Given this list of marker genes Sos1, Pak4, Cyfip2, Csk, Itga1, Myl3, Fgf15 (NCBI Gene Id 14170), Pfn1, Pik3cg, Ins1 (NCBI Gene Id 16333), Wasf2, Baiap2, Pik3ca, Rras, Pik3r4, Diaph1, Rassf7, Vil1, Chrm3, Rras2, Myl1, Fgf13, Vcl, Mapk4, Fgf17, Cfl2, Apc, Fgf16, Mapk6, Fgf4, Ssh1, Crk, Pik3r2, Mylk, Pak1, Rock1, Msn, Chrm2, Fgfr2, Rac3, Pxn, Cfl1 (NCBI Gene Id 12631), Arhgef1, Iqgap1, Pip4k2b, Fgf2, Mapk1, Gna13, Pip4k2a, Arhgef6, Pik3c3, Nckap1, Fgf9, Apc2, F2, Pip5kl1, Enah, F2r, Rock2, Fgf14, Egfr, Ppp1r12a, Mos, Map2k1 (mitogen-activated protein kinase kinase 1), Fgf18, Pip5k1b, Brk1, Pik3cb, Fgf1, Rdx, Fgfr1, Fgf6 (fibroblast growth factor 6), Map2k2, Chrm5, Arhgef4, Fgd1, Fgf10, Fgfr4, Chrm4, Pik3c2b, Ins2, Abi2, Rac1, Pik3r3, Pdgfb (platelet derived growth factor, B polypeptide), Pik3cd, Mapk3, Wasf1, Fgfr3, Vav1, Fgf12, Mras, Sos2, Ptk2, Kras, Pak5, Bdkrb1, Bdkrb2, Pak2, Fgf23, Pik3c2g, Pik3c2a, Pik3r1, Actb, Fgf3, Actn1, Ssh3, Pdgfa, Slc9a1, Rac2, Braf, Chrm1, Fgf8, Ezr, Fgf22, Pak3, Cd14, Pip5k1a, Was, Fgf7, Pdgfra, Fgf21, Nras, Bcar1, Actg1, Cdc42, Tmsb4x, Myh10, Fgf20, Git1 (NCBI Gene Id 63992), Ssh2, Pip5k1c, Raf1, Pik3r5, Dock1, Gsn, Gna12, Arhgap35, Fn1, Gng12, Pak6, Pdgfrb, Fgf5, Arpc5, Egf, Limk1, Pip4k2c, Arhgef7, Rhoa, Diaph3, here is a description of the gene set: Regulation of actin cytoskeleton species: Mus musculus Mouse Gene Set: WP_REGULATION_OF_ACTIN_CYTOSKELETON